Given this list of marker genes Cpsf6, Fn1, Eml4, Dbn1 (NCBI Gene Id 56320), Rap1a, Myo5c, Crybg3, D630045J12Rik, Ctcf, Ankrd28, Ikzf5, Onecut2, Prkg1, Pdzd11, B3glct, Bmi1, Klf13, Sorbs1, Asap1, Palm3, Zfp68, Gabpb1, Thoc2, Nrg2, Mybl1, Evi2a (NCBI Gene Id 14017), Trhde, Rtl4, Pip4k2a, Plxnc1, Spata17, Ccr2, Magi3, Aldh7a1, Tenm4, Phf1, Apbb2, Mdga2, Zfp345, Zic1, Mapk9, Slc29a3, Zeb2, Pms1, Sfxn3, Cep70, Ramacl, Upf3b, Meioc, Zfp1005, Zgrf1, Ppargc1a, Fem1b, Prkg2, here is a description of the gene set: species: Mus musculus from publication Chen Y, Wang X (PMID 31504780) Genes predicted to be targets of miRBase v22 microRNA mmu_miR_6937_5p in miRDB v6.0 with MirTarget v4 prediction scores > 80 (high confidence targets). Mouse Gene Set: MIR_6937_5P